The following is a description of a gene set: studied in species Mus musculus Postmitotic nuclear pore complex (NPC) reformation Mouse Gene Set: REACTOME_POSTMITOTIC_NUCLEAR_PORE_COMPLEX_NPC_REFORMATION, and this is the list of marker genes: Nup35, Ahctf1, Sec13, Nup133, Rangap1, Nup98, Ndc1, Ran, Nup93, Seh1l, Nup107, Ube2i, Nup205, Nup155, Sumo1, Nup160, Nup188, Nup37, Rcc1 (NCBI Gene Id 66739), Nup85, Pom121, Nup43